Given this list of marker genes NTRK1, SUGP1, TFAM, RAB2A, TFPI, IBTK, MYH14, ILRUN, NBL1, SIX1, G3BP2, PITX3, MTARC2, ADAMTSL3, CCDC40, SYNE1, DBNDD1, GIPC2, GRK6, MAPK8IP3, DAG1, GALK1, NDN (necdin, MAGE family member), SLC25A10, SNCAIP, CLCF1, HNRNPA3P17, CDC42EP4, PDE4A, SLC24A3, LRFN4, BYSL, SFI1, OXLD1, ADCY9, ADGRF5, FGF8, HMGA1, MAN2A1, PAX8, ODF2, ASAH1, JAM2, ZBTB16, ANAPC13, ICMT, KRT13, RASA1, FOXO3, RB1CC1, CCDC106, ADO, NKX2-8, TLE3, CREBBP, SPI1 (NCBI Gene Id 6688, Spi-1 proto-oncogene), VCX, SH2D3A, F2R, SCAMP1, SPATA7, HMGB3, TRMT2A, PDGFD, RECK, RAB6A, MYO9B, TRAF3, HAUS5, ITM2B, NMT2, AGTR1 (angiotensin II receptor type 1), KCNQ1, DHX29, MORC3, EPS8, FZR1, ZNF235, MAOA, ARMC8, DNASE1L2, FBXO38, LEPR, CGREF1, PDGFRA, IGHE, IKBKE, SEMA3F, FAM106A, VAC14, NR2F1, ZEB1 (zinc finger E-box binding homeobox 1), FCHO1, BTF3, SUGP2, ZNF16, TIAM1, RPS6KA2, SEC63, FILIP1L, LPAR2 (lysophosphatidic acid receptor 2), IL18BP, MATK, STK39, NT5E, SELENOP, MAST3, CILP, RARRES1, SPDEF, SIRT7, DNAJB4, DCAF15, HOXD3, CRTC3, ADAM8, CCSER2, COPS8, TADA2A, ARHGAP35, CDYL, COLGALT1, RAPGEF1, C7, DKC1, MEOX2, ZFPL1, NADK, BAIAP2, CCDC69, KRT10, SNX3, CDK19, SKIC3, CAMK2N1, CSF1, GRM4, COL15A1, JAM3, RNASE4, CHAF1A, DEF6, STXBP2, TNKS, KCNK12, CERK, FKBP8, IQCE, SOCS2, AKAP7, RAD17, BNIP3L (BCL2 interacting protein 3 like), RHOT1, NBEAL2, PCGF3 (NCBI Gene Id 253443), LPAR1, HHLA2, POLD1, PJA2, TMEM47, ZER1, RRP1, EIF2AK3, KRT8P11, LMOD1, MINDY2, AVPR2, SDC2, RARB, PEX3, ESRRA, OGFR, DNASE2, ZNF696, TNPO2, TELO2 (NCBI Gene Id 9894), REEP5, PRKACA, VPREB1, ACO1, EFEMP1, THAP10, EPN1, CHST8, MAP2K3, REV3L, RAP2A, DUS1L, METTL3, ARHGEF2, CDKN2D, PAM, SNX2, SEPTIN7, REXO4, PLPP3, TRMT61A, MERTK, HMGCR, KDELR3, TLE4, KAT2B, MAPK8IP1, GMIP, CAMK2A, CDK11B, TNPO1, HDAC4, FUT4, TRMT1, TYMP, PPP3CB, STAT2, PCDHA9, CSGALNACT2, GLS, SPART, ACSL3, OBSL1, SMAGP, CCNH, EDNRA, UBE2B (NCBI Gene Id 7320), TNFRSF25, IPO4, ATXN2L, STAT5B, RANBP2 (NCBI Gene Id 5903), DUSP7, PATJ (PATJ crumbs cell polarity complex component), TSPAN7, FNDC3A, CD164, TM2D1, IKBKB, IRAK3, FEZ1 (NCBI Gene Id 9638), PSD4, ASB6, PPP3CA, IGFBP3, CDHR5, WIZ, ZNF839, CALCOCO2, ELL, MRPS27, LARP6, TMED7, BCAT2, AP1M2, EPB41L3, ITM2A, GCDH, ARMC6 (armadillo repeat containing 6), SPRED2, ARHGEF10 (Rho guanine nucleotide exchange factor 10), PDS5B, SERPINB7, JRKL, RAD54L, GOSR2, SLC30A5, MYOF, AKAP10, H2BC9, CCDC22, RCC1, DIMT1 (NCBI Gene Id 27292), CPSF1, MAU2, LRRC8E, ADAM15, RAI14, YIPF2, DDX11, ERLIN2, ZNF518A (zinc finger protein 518A), RNASEH2B, ARHGEF1, GATM, DDX52, TMEM223, STOM, CD302, SCAPER, SBF1, HOOK2, ANKRA2, PKP3, DEDD, DTNB, FAAP100, WNT5A, APC, F8, PDCD5, LAD1, PRKAR1A, PNISR (NCBI Gene Id 84956), SEMA3C, AMIGO2, SIPA1, RND1, SS18, HNRNPH1, ANXA6, AAAS, AZI2, PPAN, IL6ST, PEG3, GAS2L1, UBL3, SSX2IP, ENPP2, RHOBTB3, POLR2M, GULP1, AP1G2, U2AF2, GNAI1, NEUROG3, NID1, CC2D1A, CAV2, FRMD4A, IGF2, MMUT, KDR, PDZRN3, EOGT, GPRASP1, FAM83E, HEPH, ACOT7, FUBP3, COL13A1, MSH5, PBX2P1, MAP3K5, H2BC10, TAX1BP1, DLG3, ASPSCR1, LIMCH1, DHX9, ARB2A, ZNF444, AMH, CDC40, NR2F2, SPOCK1, TWNK, CPQ, SLC35C1, YTHDC2, EID1, MECP2, TGFB1I1, FBXL5, GNE, SMPDL3B, ADAMTS8, ITGB4, CRTAP, CYRIA, UPF1, CBX6, SPARCL1, GSTM5, STK4, HNRNPA1, PAPSS2, PHF14, HERC1, PDE8A, ESPL1, DCAF11, ADRA1A, KL, TCF15, BST1, EXOC7 (NCBI Gene Id 23265), PAOX, RARG, CNGB1, ATP8B4, APEX2, HOMER3, ECM2, PTGER3, RANBP3, WAS, SYK, MEF2C, CDK2, DCHS1, CDK3, HDHD3, CDK16, ARHGAP6, NAT8B, DKK2, MTAP, RARRES2, FAT4, MYBL2, LEFTY2, SESN1, MRTFB, BAMBI, PTPRS, GTF3C2, H2BC7, COL21A1, SPOP, TREX2, EHMT2, KRT19P2, CREB3L2, TICAM1, CDK5RAP2, ADAMTS7, GPR68, H2BC3, PSD3, PIK3R1, BOP1, LRRFIP2 (LRR binding FLII interacting protein 2), PHACTR2, IFNAR2, KRI1, KCNAB1, OTUB1, SRRT, ABCA8, IGFBP4, NBR2, CCPG1, ALOX5, ST13, PDSS2, WFS1, FARSA, DST, COX5AP1, ATP6V1C1, CDK14, H2BC6, WBP4, ABCG2, THSD7A, CDK18, MICB, SIRT1, IGFBP5, PRKD3, MAOB, VPS13C, CR1, CAVIN1, YIPF6, TMEM168, PACSIN3, RUNX1T1, KLK5, MAPKAPK3, SEC23IP, MAP4K2, GPR39, FKBP14, VAV2, SNAI2, SETD2, BICD1 (BICD cargo adaptor 1), DLAT (dihydrolipoamide S-acetyltransferase), VAV1, HNRNPU (NCBI Gene Id 3192), DNAJB9, RB1, FOXC2, NHLRC2, CAV1, TRPC1, CDR2, CLN6, RPAP2, EDEM3, WDR77, PCDH17 (protocadherin 17), PTPRD, SLC12A4, PIK3R2, DENND4A, PTPRN2, DCN, ZFYVE16, TNNI2, SLC47A1, SRSF11, IRS1, ZCCHC24, PDE1A, TWF2, ECE1, here is a description of the gene set: species: Homo sapiens Despite the existence of morphologically indistinguishable disease, patients with advanced ovarian tumors display a broad range of survival end points. We hypothesize that gene expression profiling can identify a prognostic signature accounting for these distinct clinical outcomes. To resolve survival-associated loci, gene expression profiling was completed for an extensive set of 185 (90 optimal/95 suboptimal) primary ovarian tumors using the Affymetrix human U133A microarray. Cox regression analysis identified probe sets associated with survival in optimally and suboptimally debulked tumor sets at a P value of <0.01. Leave-one-out cross-validation was applied to each tumor cohort and confirmed by a permutation test. External validation was conducted by applying the gene signature to a publicly available array database of expression profiles of advanced stage suboptimally debulked tumors. The prognostic signature successfully classified the tumors according to survival for suboptimally (P = 0.0179) but not optimally debulked (P = 0.144) patients. The suboptimal gene signature was validated using the independent set of tumors (odds ratio, 8.75; P = 0.0146). To elucidate signaling events amenable to therapeutic intervention in suboptimally debulked patients, pathway analysis was completed for the top 57 survival-associated probe sets. For suboptimally debulked patients, confirmation of the predictive gene signature supports the existence of a clinically relevant predictor, as well as the possibility of novel therapeutic opportunities. Ultimately, the prognostic classifier defined for suboptimally debulked tumors may aid in the classification and enhancement of patient outcome for this high-risk population. Human Gene Set: BONOME_OVARIAN_CANCER_SURVIVAL_SUBOPTIMAL_DEBULKING from publication Bonome T, Levine DA, Shih J, Randonovich M, Pise-Masison CA, Bogomolniy F, Ozbun L, Brady J, Barrett JC, Boyd J, Birrer MJ (PMID 18593951) Genes whose expression in suboptimally debulked ovarian tumors is associated with survival prognosis.